The following is a description of a gene set: Human Gene Set: MIR3977 from publication Chen Y, Wang X (PMID 31504780) species: Homo sapiens Genes predicted to be targets of miRBase v22 microRNA hsa-miR-3977 in miRDB v6.0 with MirTarget v4 prediction scores > 80 (high confidence targets)., and this is the list of marker genes: CST8, PHF20L1, TBL1XR1, HTR5A, LNX2, HDAC2, SEMA5A, AVEN, FAM8A1, NMBR, CDH5, CEP68, CWF19L2, SGCZ, ARID1B, MIP, CDKN1B, C8orf44-SGK3, BEND3, NEBL, TENT2, CLIC5 (chloride intracellular channel 5), ABLIM1, FZD3, BRAF, PRAME, DPPA3, ATP8A2, ENC1, UHMK1, UBE2V2, DCUN1D4, GABRB2, NRSN1, SYT1, ATP2B4, NEDD4, TMEM47 (NCBI Gene Id 83604), SMIM10 (small integral membrane protein 10), PAK3, RUBCN (NCBI Gene Id 9711), PKNOX1, GPCPD1, ENPEP, NDUFAF5, LRRC8A, SYF2, WWP1, TMCO1, HOXA5, TRIM44, CMKLR2, SCN2A, SGK3, AGO1, MTARC1, MIS18A, CRIPT, CERT1, GPATCH2, ABCB10, CUL4B, TAC1, XIRP2, RALGAPB, FAM237A, UBE2V1, SLC8A1, AP4B1, PAQR9 (progestin and adipoQ receptor family member 9), MIER1, CMPK1, HAPLN1, ENSG00000275993, CPT1A, RYR2, ZIC3, KIAA1549, TMEM164, FBXO47, HIVEP2, ZDHHC17, UNC5D, MOCS2, RASAL2, VTA1, KCNK9, FAM118A, CRISPLD2, COMMD9, PHF20, RAB11B, NR3C2, UGP2, LEAP2, GZF1, LIN28B, TMX4, CNOT6, SYT16, CANX, MOB1A, SIK1, G6PC1, SFMBT1, STK3, RAVER2, CARTPT, ICA1L, SLC22A24 (solute carrier family 22 member 24), SLC6A6, NFASC, BPNT2, ARID5B (NCBI Gene Id 84159), NPAP1, RIOX2, IER5, MEX3C, MCTS1, ANKRD13C, CREBRF, MAB21L2, AK7, C2CD4A, CTCF, PALLD, NHLRC3, MOB1B, RBM48, STT3B, ARL8B, PDSS1, BAG5, ELOVL7, AMD1, TAF5L, DENND6A, MEI4, MSL1, CERS6, USP49 (ubiquitin specific peptidase 49), OPRM1, CHST9, CTDSPL, RNF14, CDYL2, MAD2L1, CLUAP1, ALCAM, PTCH1, GAR1, HBS1L, CTNND1, POF1B, HDAC9, BBX, TADA2B, TLE4, SCAI, MKKS, PMS1